Given this list of marker genes TATDN1, NCOR1, MED26, EIF2S2, CDT1, GABPB1, METTL22, GLYCTK, KLHL22, DPM1, ASNS, here is a description of the gene set: from publication Pos Z, Wiener Z, Pocza P, Racz M, Toth S, Darvas Z, Molnar V, Hegyesi H, Falus A (PMID 18339882) Human Gene Set: POS_RESPONSE_TO_HISTAMINE_DN Genes gradually down-regulated by histamine in B16-F10 melanoma tumors. species: Mus musculus We previously showed that transgenic enhancement of histamine production in B16-F10 melanomas strongly supports tumor growth in C57BL/6 mice. In the present study, gene expression profiles of transgenic mouse melanomas, secreting different amounts of histamine, were compared by whole genome microarrays. Array results were validated by real-time PCR, and genes showing histamine-affected behavior were further analyzed by immunohistochemistry. Regulation of histamine-coupled genes was investigated by checking the presence and functional integrity of all four known histamine receptors in experimental melanomas and by administering histamine H1 receptor (H1R) and H2 receptor (H2R) antagonists to tumor-bearing mice. Finally, an attempt was made to integrate histamine-affected genes in known gene regulatory circuits by in silico pathway analysis. Our results show that histamine enhances melanoma growth via H1R rather than through H2R. We show that H1R activation suppresses RNA-level expression of the tumor suppressor insulin-like growth factor II receptor (IGF-IIR) and the antiangiogenic matrix protein fibulin-5 (FBLN5), decreases their intracellular protein levels, and also reduces their availability in the plasma membrane and extracellular matrix, respectively. Pathway analysis suggests that because plasma membrane-bound IGF-IIR is required to activate matrix-bound, latent transforming growth factor-beta1, a factor suggested to sustain FBLN5 expression, the data can be integrated in a known antineoplastic regulatory pathway that is suppressed by H1R. On the other hand, we show that engagement of H2R also reduces intracellular protein pools of IGF-IIR and FBLN5, but being a downstream acting posttranslational effect with minimal consequences on exported IGF-IIR and FBLN5 protein levels, H2R is rather irrelevant compared with H1R in melanoma.